Given this list of marker genes MAP2K2, BRAF (NCBI Gene Id 673), MAPK3, MAP2K1, MAPK1 (mitogen-activated protein kinase 1), here is a description of the gene set: species: Homo sapiens Human Gene Set: KEGG_MEDICUS_VARIANT_MUTATION_ACTIVATED_BRAF_TO_ERK_SIGNALING_PATHWAY Mutation-activated BRAF to ERK signaling pathway. Pathway ID: N00013. Pathway type: Variant. Pathway class: nt06268 Melanoma. Pathway Definition from KEGG: BRAF* -> MEK -> ERK